Given this list of marker genes RPS6KB1, MRC1, ACTR2, IFNGR1, GBP2, ACTR3, DAPK1, SP100, ASS1, VIM (NCBI Gene Id 7431), CD47, STXBP2, HCK, AQP4, PPARG (NCBI Gene Id 5468, peroxisome proliferator activated receptor gamma), RPL13A, CCL2, SYNCRIP, STXBP3, CLDN1, IRF8, IRF1, GAPDH (NCBI Gene Id 2597), IL12RB1, PDE12, NLRC5, KIF5B, CRIPTO, ARG1, VPS26B (NCBI Gene Id 112936), GBP1, TXK, IFNGR2, STXBP4, JAK2, PARP9, TYK2, JAK1, DNAJA3, ACTG1, RAB43, GBP4, IRGM, EPRS1, SLC26A6, STXBP1, TLR4, OTOP1, FASLG, TNF, CD58, NR1H3, HPX, STX4, CCL5, RAB20, GBP7, CALM1, SIRPA, CDC42, STX8, CDC42EP4, ADAMTS13, CDC42EP2, TLR2, TLR3, PARP14, WNT5A, GBP5 (NCBI Gene Id 115362), EDN1, IFNG, ZYX, VAMP3, CD200, NOS2, RAF1, DAPK3, GBP3, AIF1, CASP1, WAS, CAMK2A, IL12B, ACOD1, MYO1C, PTPN2, GSN, PIM1, FCAR, GBP6, FLNB, VAMP4 (vesicle associated membrane protein 4), LGALS9, CDC37, HLA-DPA1, STAT1, CIITA, CCL3 (NCBI Gene Id 6348), MED1, NR1H2, TP53, RAB7B, here is a description of the gene set: Human Gene Set: GOBP_CELLULAR_RESPONSE_TO_TYPE_II_INTERFERON Any process that results in a change in state or activity of a cell (in terms of movement, secretion, enzyme production, gene expression, etc.) as a result of an interferon-gamma stimulus. Interferon gamma is the only member of the type II interferon found so far. species: Homo sapiens